The following is a description of a gene set: species: Homo sapiens Human Gene Set: HP_ABNORMAL_CHROMOSOME_MORPHOLOGY Any structural anomaly of a chromosome, which is a thread like molecule consisting of DNA and proteins (chromatin) that contains DNA sequences for genes and other genetic elements in linear order. Abnormal chromosome morphology, and this is the list of marker genes: DNAJC21, RPA1, ACD, MDM4, TINF2, POT1, PARN, WRAP53, TERT, TYMS, NOP10, ZCCHC8, TP53, RTEL1